Given this list of marker genes HES1, KDM2B, FGF8, GBX2, WNT1, EN1, SSBP3, here is a description of the gene set: Human Gene Set: GOBP_MIDBRAIN_HINDBRAIN_BOUNDARY_DEVELOPMENT species: Homo sapiens The process whose specific outcome is the progression of the midbrain-hindbrain boundary over time, from its formation to the mature structure. The midbrain-hindbrain domain of the embryonic brain is comprised of the mesencephalic vesicle and the first rhombencephalic vesicle at early somitogenesis stages.